The following is a description of a gene set: Genes positively differentially expressed in cell type: Treg upon treatment with cytokine: IL-27 in mouse lymph nodes in vivo. from publication Cui A, Huang T, Li S, Ma A, Pérez JL, Sander C, Keskin DB, Wu CJ, Fraenkel E, Hacohen N (PMID 38057668) Cytokines mediate cell-cell communication in the immune system and represent important therapeutic targets. A myriad of studies have highlighted their central role in immune function, yet we lack a global view of the cellular responses of each immune cell type to each cytokine. To address this gap, the authors created the Immune Dictionary, a compendium of single-cell transcriptomic profiles of more than 17 immune cell types in response to each of 86 cytokines (>1,400 cytokine-cell type combinations) in mouse lymph nodes in vivo. A cytokine-centric view of the dictionary revealed that most cytokines induce highly cell-type-specific responses. For example, the inflammatory cytokine interleukin-1β induces distinct gene programmes in almost every cell type. A cell-type-centric view of the dictionary identified more than 66 cytokine-driven cellular polarization states across immune cell types, including previously uncharacterized states such as an interleukin-18-induced polyfunctional natural killer cell state. studied in species Mus musculus Mouse Gene Set: CUI_TREG_IL27_RESPONSE_UP, and this is the list of marker genes: Idnk, Psmb10, H2-K1, Ly6a, Isg20, Gimap4, Psmb9, Stat1, Igtp, Tap1, Cd2, Tap2, Zbp1 (Z-DNA binding protein 1), Atp2c1, Psmb8, Bst2, Ifi27l2a, Ifi47 (interferon gamma inducible protein 47), H2-T23